Given this list of marker genes Ranbp9, Muc20, Hgf, Sos1, Met, Shc1, Kras, Hras, Ranbp10, Grb2, here is a description of the gene set: Mouse Gene Set: REACTOME_MET_ACTIVATES_RAS_SIGNALING MET activates RAS signaling studied in species Mus musculus